The following is a description of a gene set: species: Homo sapiens Any process that decreases the rate or extent of cholesterol storage. Cholesterol storage is the accumulation and maintenance in cells or tissues of cholesterol, cholest-5-en-3 beta-ol, the principal sterol of vertebrates and the precursor of many steroids, including bile acids and steroid hormones. Human Gene Set: GOBP_NEGATIVE_REGULATION_OF_CHOLESTEROL_STORAGE, and this is the list of marker genes: ABCA1, TREM2, PPARA (peroxisome proliferator activated receptor alpha), MIR146A, CES1, TTC39B, ABCG1, NR1H3, PPARD, PPARG, NR1H2